The following is a description of a gene set: species: Mus musculus The process in which ions are transported across a membrane such that the atrial cardiomyocyte membrane potential changes in the direction from the positive membrane potential at the peak of the action potential towards the negative resting potential. Mouse Gene Set: GOBP_MEMBRANE_REPOLARIZATION_DURING_ATRIAL_CARDIAC_MUSCLE_CELL_ACTION_POTENTIAL, and this is the list of marker genes: Kcnn2, Flna, Kcnj5, Kcnq1, Kcna5